The following is a description of a gene set: Human Gene Set: GOBP_REGULATION_OF_IMMUNE_EFFECTOR_PROCESS Any process that modulates the frequency, rate, or extent of an immune effector process. studied in species Homo sapiens, and this is the list of marker genes: BTK, VAMP8, TLR3, TNFRSF14, SNX4, PLA2G3, KLRC2, HFE, SH2D1B, PTPRC, TNF, HLA-DRB1 (NCBI Gene Id 730415), FCRL3, KLK3 (kallikrein related peptidase 3), STXBP1, TRIL, MAD2L2, HLA-C, BCR, PGLYRP1, NECTIN4, KLK7, RSAD2, RTN4, IL18RAP, ULBP2, CD86, FER, PGLYRP3, NOD2, IL27RA, MAPK3, AP1G1, EXOSC3, CLC, NCR3, IL2, FADD, GALNT2 (NCBI Gene Id 2590), HLA-DMB, TNFRSF1B, TRIM6, NOD1, HTR2A, PYCARD, HAVCR2, IL20RB (interleukin 20 receptor subunit beta), MIR520B, IL27, AZGP1, ZBTB1, TICAM1, SPON2, ASCL2, RARA, CD81, KLK5, SMAD7, DHX58, IFNA2, SPN, USP5, VAMP7, PCK1, SLC7A5, GPR65, ULBP1, CD37, HMGB1, UFL1, STAT5A, ACP5, SUPT6H, FOXF1, CCR2, GATA1, IL6, DUSP10, IL12RB1, CRK, GPI, ANKRD17, NECTIN2, YWHAG (tyrosine 3-monooxygenase/tryptophan 5-monooxygenase activation protein gamma), TLR7, CD69, SERPINB4, IL23A, TNFSF13, CLEC4G, CD80, SLC15A4, IL7R, TRAF6, BST2, IL2RG, KMT5C, FES, LOXL3, IRF5, KMT5B, RAET1L, MALT1, TREX1, CD84, ULBP3, LITAF, TNFRSF4, HLA-DRB3, DENND1B, UNC13D, IL10 (NCBI Gene Id 3586), PMS2, CD160, FERRY3, FUT7, STAT5B, PDCD1, SPHK2, FOXJ1, IL17A, FFAR3, TREM2, KLRK1, DEFB131A, LTA, IFNB1, HMCES, RAET1G, STX4, CD96, HLA-G, SERPING1, PKP3, PLA2G5, MIF, APOA1, MBL2, STAP1, JUNB, APPL2, IL13RA1, IL12B, IL4, HLA-H, CD244, HLA-A (major histocompatibility complex, class I, A), FGL2, KLRC4, CUEDC2, RAC2, LAG3, KLRB1, KLHL22, DNASE1, BCL10, DDRGK1, LILRB1, SHB, ZNF683, IL13, NLRP3, CD226, CD1B, TFRC, DHX36, GRN, RBP4, TGFB1, TBX21, ARRB2, POMC, CYRIB, TLR4, LACC1, HLA-B (major histocompatibility complex, class I, B), DDX60, TP53BP1, IL33, COLEC11 (NCBI Gene Id 78989), SERPINB9, C4BPA, FGR, CLEC7A, CD1E, MYD88, PVR, RC3H1, RIF1, IL1B, LGALS1, ATG5, CD1D, LAPTM5, RC3H2, APLF, HLA-E, ZPBP2, DUSP22 (NCBI Gene Id 56940), PRKCZ, CFH, BRD4, LILRB4, USP17L2, CR1, RIPK2, FCER2, BRD2, KLRC1, PPP3CB, COLEC10, AXL (NCBI Gene Id 558), SLAMF1, KLRC4-KLRK1, NFKBIZ, SEMA7A, CD5L, SPI1, NCF1, XBP1, CD28, C1QBP, SPINK5, MAVS, KLRD1, BATF, SHLD1, STXBP2, PANX1, AHR, FCN3, SLAMF8, P2RX7, CD22, GATA3 (GATA binding protein 3), PRKAA1, PIK3R6, IL18 (NCBI Gene Id 3606), LAMP1, NSD2, SLC22A13, EP300, MLH1 (mutL homolog 1), CD59, SH2D1A (NCBI Gene Id 4068), PARP3, XCL1, FCN2, FOXP3, ZC3H12A, IL1R1, PLCG2, CD7, MYO18A, KLRC3, SUSD4, RIPK3 (NCBI Gene Id 11035), PHB2, TAP2, CXCL6, B2M, PRAM1, PAXIP1, CAMK4, TGFB3, IL4I1, CD274, CD40LG, FBXO38, IFNG, IL4R, GRB2, NOS2, ARID5A, C4BPB, CD74, HPX, HSPD1, DDX1, ANGPT1, TNFSF18, DNAJB9 (NCBI Gene Id 4189), LYN, PGLYRP2, PTPN6, INPP5D, CLNK, STAT6, CGAS, VAV1 (vav guanine nucleotide exchange factor 1), FCGR2B, NR4A3 (nuclear receptor subfamily 4 group A member 3), RASGRP1, CD55, SYK, INS, HLX, FFAR2, S100A9, ITGB2, VAMP3, A2M, LGALS3, RAET1E, CR2, IL13RA2, CLCF1, CD36, EPHB2, MIR302A, IL23R, WNT5A, SLAMF6, CD46 (CD46 molecule), CX3CR1, PRG2, FZD5, WAS, MAPKAPK2, CD40, ZP3, SHLD2, CD1A, DNASE1L3, IL17F (NCBI Gene Id 112744), LEP, EXOSC6, PHB1 (NCBI Gene Id 5245), ZBTB7B, CD177, FCGR1A, IL21, APPL1, ATG9A, NDFIP1, MR1, GAB2 (NCBI Gene Id 9846), MSH2, TYROBP, ENPP3, STX7, SCIMP, FCER1G, MICA, CCL19, ANXA1, HLA-DRA, CALHM6, IL5, MASP1, NCR1, DDX21, ARG1, CD1C, NCKAP1L, ITGAM, KIR2DL4, CADM1 (NCBI Gene Id 337934), MZB1, NFKBID, EVPL, F2RL1, SASH3, TRAF2, IRF4, MIR21, CLEC12B, TLR9, TMBIM6, IL12A, MAP3K7, CEACAM1, TWIST1, UBE2J1, ATAD5, HLA-F, GPRC5B, EPX, RIGI, TIGIT, KIT, TRPM4, TNFSF4, C17orf99, PGC, IL18R1, IRAK3, PDPK1, CARD9, CFP, MIR520E, AGER, ICAM1, C3, ADGRE2, BCL6, LGALS9 (galectin 9), CD300A, ADORA2B, PKN1, RABGEF1, RPS19, TGFB2, SHLD3, SOCS5, APOA2, SECTM1, SIRT1, CR1L, OPA1 (NCBI Gene Id 4976), CRTAM, HK1, NLRX1, FCN1, IFNL1, RASGRP4, LBP, VSIG4, INAVA, GATA2, JAK3